The following is a description of a gene set: studied in species Homo sapiens The transcription factor FoxP3 partakes dominantly in the specification and function of FoxP3+ CD4+ T regulatory cells (Tregs), but is neither strictly necessary nor sufficient to determine the characteristic Treg transcriptional signature. Computational network inference and experimental testing assessed the contribution of several other transcription factors (TFs). Enforced expression of Helios or Xbp1 elicited specific signatures, but Eos, Irf4, Satb1, Lef1 and Gata1 elicited exactly the same outcome, synergizing with FoxP3 to activate most of the Treg signature, including key TFs, and enhancing FoxP3 occupancy at its genomic targets. Conversely, the Treg signature was robust to inactivation of any single cofactor. A redundant genetic switch thus locks-in the Treg phenotype, a model which accounts for several aspects of Treg physiology, differentiation and stability. Human Gene Set: GSE40274_FOXP3_VS_FOXP3_AND_GATA1_TRANSDUCED_ACTIVATED_CD4_TCELL_UP Genes up-regulated in CD4 T conv over-expressing FOXP3 versus GATA1 and FOXP3. from publication Fu W, Ergun A, Lu T, Hill JA, Haxhinasto S, Fassett MS, Gazit R, Adoro S, Glimcher L, Chan S, Kastner P, Rossi D, Collins JJ, Mathis D, Benoist C (PMID 22961053), and this is the list of marker genes: GABRA3, SLC6A16, ABCC10, PRR5, RPS6KL1, ASPHD1, CPE, SLIT3, MDM1, CYP4F22, KCNJ1, POU2AF1, KCNJ11, NR4A1, PEX5L, HSD17B13, TSPAN11, SLC13A1, MARCO, SLC1A2, REC8, INPP5B, MTCL1, INS, KRTAP11-1, GLT8D2, NME5, NFIB, ZNF131, ABCD3, CCNJL, CDIPTOSP, SLC36A2, TTLL11, HAP1, GDF11, TNFAIP2, TMCC2, LRRN4CL, CDH18, TAGLN3, USP11 (NCBI Gene Id 8237), PRUNE2, LENG8, TTC3, ZNF420, FBXO9, NUP155 (NCBI Gene Id 9631), NPY4R, TBX15, PNMA3 (PNMA family member 3), KRIT1, KTN1, SNPH, CBLN3, CNTNAP2, SELENBP1, RAB3IP, SLC16A6, PKP1, GARIN3, PPM1B, C1S, PRKCD, SPP2, PDILT, SPATA3, GSTZ1, IRAG2 (inositol 1,4,5-triphosphate receptor associated 2), PPP2R2B, CYP2U1 (cytochrome P450 family 2 subfamily U member 1), CD27, FOXRED1, KCNN1, DLX5, DEFB116, TRA2A, PLCG1 (NCBI Gene Id 5335, phospholipase C gamma 1), NOC3L, CDC45, LDHAL6B, TMEM37, COG3, ENTREP1, GAL, OPN4, DOCK1, VEGFA, MYOZ3, DYNC2I1, ANKRD23, MEG3, KCNA5, SYT1, MRAS, PLBD1, ACTN2, PDE6H, SLC9A1, EVI2A, TRIP12, DNAH8, H2AB2, ZFP37, DPP6, EFNA4, PKDCC, CLN3, NETO1, SDSL, CNTLN, FMNL3, ST18, ARHGAP18, F2, ZNF423, PRDM10-DT, TSG101, ZCCHC12, DNAL1, SH3PXD2B, OMP, CNFN, SYNGR4, ARPP21, GPR45, RNF144A, SLC45A2, METTL8, SLCO1A2, INTU, STAC2, PYGM, ABCC5, CDX2, KLF5, DMBX1, KCNH8, FES, ASB11, QSER1, HNRNPA1, SSPOP, SCAI, KCNQ5, CDH17, MATN2, VSX2, TBC1D22B, CLRN3, GRHL2, TBC1D4, NSMAF, XRCC2, ILF3, GAL3ST2, ADGRL1 (NCBI Gene Id 79732), OSBP2, CAMK2B, USP42, ABCA4, C16orf90, PLGRKT, ADD1, PTPRU, PRSS12, CTPS1, FGFR2, NRGN, CDC42BPG, SAPCD2, MPL, CCDC125, APOB, TMCO2, SPNS2, F13B, ZNF219, TCERG1, CALB1, PROX2, C16orf96, BCLAF1, SEMA4A, SMTNL2, TMEM213, DYNC2H1, MSH2, PTPRG, EVI2B, HMGXB4, REM2, CHML, PARP11, ARG1, EIF4G2, DENND2B (NCBI Gene Id 6764), ZC3H12C, ITGA9, TACC2